The following is a description of a gene set: Any process that increases the frequency, rate or extent of the chemical reactions and pathways resulting in the metabolism of collagen, any of a group of fibrous proteins of very high tensile strength that form the main component of connective tissue in animals. species: Homo sapiens Human Gene Set: GOBP_POSITIVE_REGULATION_OF_COLLAGEN_METABOLIC_PROCESS, and this is the list of marker genes: AMELX, SUCO, F2, F2R, CREB3L1, SCX, TGFB1, VSIR, DDR2, PRDX5, WNT4, CBX8, MYB, LARP6, VIM, INHBA, IHH, RGCC, TGFB3, UCN, RUNX1, SERPINF2, SERPINB7, MIR149, BMP4, ITGA2